Given this list of marker genes TCOF1, FRAS1, GDF6, RTTN, GTF2H5, MYRF, PTCH1, STRA6, FAM111A, TARS1, CAPN15, FIG4, MPLKIP, PUF60, AARS1, GDF3 (NCBI Gene Id 9573), RNF113A, GTF2E2, MED13L, CARS1, VAC14, PAX6, ERCC2, ERCC3 (ERCC excision repair 3, TFIIH core complex helicase subunit), SHH, ERCC1, here is a description of the gene set: studied in species Homo sapiens Human Gene Set: HP_BILATERAL_MICROPHTHALMOS A developmental anomaly characterized by abnormal smallness of both eyes. Bilateral microphthalmos